The following is a description of a gene set: Mouse Gene Set: GOCC_LATERAL_PART_OF_CELL The region of a polarized cell other than its tips or ends (in some cell types, one end may be called the apex and the other the base). For example, in a polarized epithelial cell, the lateral part includes the cell sides which interface adjacent cells. species: Mus musculus, and this is the list of marker genes: Kcne3, Numa1, Rapgef3, Vamp8, Kcnq1, Slc26a5, Spag6l, Gpsm2